Given this list of marker genes SRC, FGG, GRB2, RAP1B, PDPK1, ITGB3, PTK2, SHC1, CRK, RAPGEF4, RASGRP2, SYK, APBB1IP, PTPN1 (NCBI Gene Id 5770), FGA, FN1, RAPGEF3, ITGA2B, RAP1A, CSK, TLN1, AKT1, FGB, VWF, RASGRP1, SOS1, BCAR1, here is a description of the gene set: Human Gene Set: REACTOME_INTEGRIN_SIGNALING studied in species Homo sapiens Integrin signaling